Given this list of marker genes Psmb4, Dhh (desert hedgehog), Rps27a, Psmd1, Psmd6, Psmc5, Itch, Psma6, Psma3, Numb, Cul3, Dzip1, Psma2, Gli2, Psma1, Psmd7, Psmb7, Psmc3, Psmb1, Evc2, Psmc6, Gas1, Psmb6, Shh, Uba52rt, Sufu, Psmc1, Kif3a, Smo, Psma4, Psmb5, Psmc2 (proteasome (prosome, macropain) 26S subunit, ATPase 2), Grk2, Psmd14, Psma5 (proteasome subunit alpha 5), Psmd3, Evc, Smurf2, Arrb2, Psmb3, Uba52, Adrm1, Ptch1, Arrb1, Ubc, Psmd13, Psmd8, Csnk1a1 (NCBI Gene Id 93687), Ulk3, Psmd12, Gli3, Kif7, Rbx1, Cdc73, Spop, Gpr161, Gli1, Smurf1, Cdon, Spopl, Ihh, Psmd11, Hhip, Psmb2, Psmc4, Gas8, Psmd2, Psma7, Ubb, here is a description of the gene set: Mouse Gene Set: REACTOME_HEDGEHOG_ON_STATE species: Mus musculus Hedgehog 'on' state